The following is a description of a gene set: Binding to a component of the extracellular matrix. Mouse Gene Set: GOMF_EXTRACELLULAR_MATRIX_BINDING species: Mus musculus, and this is the list of marker genes: Tnxb, Polr2a, Spp1, Zan, Ambp, Adgrg6, Itga2, 2300002M23Rik, Ctss (NCBI Gene Id 13040), Itga9, Olfml2b, Itga6, Itgb3, Plekha2, Sparcl1, Adamts15, Spock2, Adgrg1, Dmp1 (dentin matrix protein 1), Bgn, Adamts5, Lypd3, Dag1, Thbs1 (thrombospondin 1), Olfml2a, Clec14a, Eln, Shh, Itga3, Lgals1, Lrrc15, Sparc, Pxdn, Ache, Tgfbi, Adamtsl5, Nid1, Ltbp1, Bcam, Ssc5d, Gpc1, Tinagl1, Chadl, Ntn4, Anxa2, Spock3, Smoc2, Lgals3, Adam9, Vtn, Itga7, Thbs4, Itgav, Agrn, Spock1, Fbln2, Ccn1, Fkrp, Cd248, Itga2b, Thsd1, Itgb1, Ncl, Dcn, Rpsa, Adamtsl2, Smoc1, Ltbp2, Vwa1, Slit2 (slit guidance ligand 2)